The following is a description of a gene set: Highly calcium permeable postsynaptic nicotinic acetylcholine receptors Mouse Gene Set: REACTOME_HIGHLY_CALCIUM_PERMEABLE_POSTSYNAPTIC_NICOTINIC_ACETYLCHOLINE_RECEPTORS studied in species Mus musculus, and this is the list of marker genes: Chrnb2, Chrna5, Chrnb3, Chrna7, Chrna6, Chrnb4, Chrna2, Chrna3, Chrna4 (cholinergic receptor, nicotinic, alpha polypeptide 4), Chrna9, Chrna1